Given this list of marker genes BMPR2, ZNF462, RASSF1, E2F3, SLC6A8, ID4, FUT8, CAMKK2, RPS6KA5, NBEA, UBN1, MEIS1, MSI1, VEGFA (vascular endothelial growth factor A), SCAND2P, PTPRN, RASAL2, TRIOBP, EDA (ectodysplasin A), DDX3X, SUGP1, PLPPR4, RSBN1, DDX3Y (DEAD-box helicase 3 Y-linked), RASA1, FAM53C, EP300 (NCBI Gene Id 2033), FHL3, AGPAT4, PDGFRA, NSD2, KMT2A, BTBD7, KPNB1, ARID1B, NDEL1, ACP4, KLF13, EFL1, AKIRIN1, CPLX3, MAGIX, UNC45A, UBE2D2, COL2A1, FRMD4A, NRG1 (NCBI Gene Id 653104), HOXB8, MAP3K20, ATXN2L, GRIN1, TAB2, INO80, MRFAP1, KLK6, PPM1F, TFDP2, CCDC184, RICTOR, RPS6KB1, SOX6, ARHGEF37, MINK1, SEPTIN3, ZIC4, ZNF607, CTNND1, DDX50, here is a description of the gene set: Human Gene Set: GTGTGAG_MIR342 Genes having at least one occurence of the motif GTGTGAG in their 3' untranslated region. The motif represents putative target (that is, seed match) of human mature miRNA hsa-miR-342 (v7.1 miRBase). species: Homo sapiens